The following is a description of a gene set: Any process that results in a change in state or activity of a cell (in terms of movement, secretion, enzyme production, gene expression, etc.) as a result of a progesterone stimulus. Mouse Gene Set: GOBP_CELLULAR_RESPONSE_TO_PROGESTERONE_STIMULUS studied in species Mus musculus, and this is the list of marker genes: Acod1, Vps54, Cyp1b1, Sox10, Trerf1, Src